Given this list of marker genes Akr1b7, Adh1, Cbr1, Kcnab3, Adh6a, Adh4, Rdh11, Rdh19, Akr1c19, Akr1c12, Rdh14, Hsd17b6, Cbr3, Akr7a5, Dhrs7, Dcxr, Akr1c18, Dhrs9, Akr1c14, Cbr2, Rdh13, Adh5, Rdh16, Rdh1, Rdh12, Akr1b1, Rdh5, Sdr16c5, Akr1c21 (NCBI Gene Id 77337), Akr1c20, Sdr9c7, Dhrs4, Sord, Dhrs1, Rdh8, Rdh10, Cbr1b, Rdh7, Akr1b8, Dhrs7c, Dhrs2, Adh6b, Akr1a1, Aldh3a1, Akr1b10, Rdh9, Rdh16f2, Adh7, Akr1cl, Adhfe1, Kcnab1, Akr1d1, Kcnab2, Akr1c6, Hsd17b13, Dhrs3, Miox, Dhrs7l, Akr1e1, Akr1c13, here is a description of the gene set: Mouse Gene Set: GOMF_ALCOHOL_DEHYDROGENASE_NAD_P_PLUS_ACTIVITY Catalysis of the reaction: an alcohol + NAD(P)+ = an aldehyde or ketone + NAD(P)H + H+. studied in species Mus musculus